Given this list of marker genes FHIP2A (NCBI Gene Id 57700), BLTP3A, CD27, ITPKB, GLT8D1, AHR, AR, RAB2B, FMO5, LMTK2, MTA3, FRRS1, TAX1BP3, NACC1, MBD1, PLEKHA7, RUNX1, BMP2K, FAM3A, ARFGEF2, ENTPD1, UCK2, IFT20, VPS33B, CIZ1, ARL8A, CHST15, HDAC3, DLG4, TNFRSF10B, CD44, BSCL2, IQCE, JARID2 (NCBI Gene Id 3720), WASL, PML, BCS1L, CD99L2, HSH2D, IRF2BP2, CD80, HIPK2, IFITM3, LNX2, ARHGAP17, FOXO4, POMT2, ZFAND2B, GOLGA2, TTLL1 (NCBI Gene Id 25809), GHDC, GGT7, NCF1, ST6GAL2, PTPRJ (protein tyrosine phosphatase receptor type J), GATA3, GRINA, FOSL2, P2RY14, DESI1, ZFP36, SCMH1, ACBD6, LIX1L, CAT, AXL (AXL receptor tyrosine kinase), ATXN7L1, LRRC8D, BRD4 (NCBI Gene Id 90616), LRRC61, EXTL3, PIAS3, CRTC2 (NCBI Gene Id 200186), FAM117B, MVB12B, NUP35, MFSD11, ARID5B, SLC9A7, PARD6G, MXD1, DYM, WASHC3, NDUFS7, NAAA, BCL10, PIK3R5, POU2F2, IFIT1, IRF2, MAPK1IP1L, DNAAF5 (dynein axonemal assembly factor 5), ETV6, WIPF1, EGR1, DAPP1, PLAGL2, ATP6V0A1, TAF8, TERT, NMNAT1, FKBP15, CITED2, DNAJC11, MRPL57, FLOT2, F2RL1, USP21, HCFC1, EIF4A3, WNK1, ABCC4, LAMC1, RAPH1, FXYD5, TGFBRAP1, NFAT5, ANXA1, LAMTOR2, DCAF12, ANKRD10, LRRC57, RBMS2, WBP11, UBE2R2, LPAR6, SNORD73A, PMM1, ULK3, SGPP1, SRGN, ABCA1, FBRSL1, SESN2, CCNK, WIPF2, KDM6B, CLPP, CD4, TEX15, MIR190B, TOM1, POU2F1, POLR2H, CALCOCO1, FEM1B, TET1 (NCBI Gene Id 80312), HELZ, BCL6, LY96, SLC35E2A, KDM5C, MFHAS1, NABP2, NSUN3, KCTD6, NEU3, UPRT, NAB2, PRCP, METTL15, ZDHHC9, PPP1R16B, ARID1B, MINK1, TAF6, INSYN2B, TRIM13 (tripartite motif containing 13), H1-3, IRS2, PSMA1 (NCBI Gene Id 5682), STRADB, RAB4B, CASP8, TRAM2, WDR46, here is a description of the gene set: species: Homo sapiens Human Gene Set: GSE37532_WT_VS_PPARG_KO_LN_TREG_UP Genes up-regulated in T reg from lypmh nodes of elderly (retired breeder) mice: wildtype versus PPARG knockout. We identified Pparg as a major orchestrator of the phenotype of adipose-tissue resident regulatory T cells (VAT Tregs). To establish the role of Pparg in shaping the VAT Tregs gene profile and cell dynamics, Tregs from lymph nodes and visceral adipose tissue of mice sufficient and deficient of Pparg expression in Tregs were double sorted for microarray analysis. from publication Cipolletta D, Feuerer M, Li A, Kamei N, Lee J, Shoelson SE, Benoist C, Mathis D (PMID 22722857)